The following is a description of a gene set: species: Homo sapiens Any process that stops, prevents, or reduces the frequency, rate or extent of membrane protein ectodomain proteolysis. Human Gene Set: GOBP_NEGATIVE_REGULATION_OF_MEMBRANE_PROTEIN_ECTODOMAIN_PROTEOLYSIS, and this is the list of marker genes: TIMP4, TIMP1, TIMP3, LRIG2, TIMP2, PTPN3, IL10, ROCK1